The following is a description of a gene set: Neighborhood of AATF Human Gene Set: MORF_AATF species: Homo sapiens Neighborhood of AATF apoptosis antagonizing transcription factor in the MORF expression compendium, and this is the list of marker genes: XRCC5, ALG3, PIN1, DDX18, PPP2CA, ZBED1, CSK, CANX, PUM2, DNAJC11, SDHA, FIBP, PSMB7, POLR2I (RNA polymerase II subunit I), NUP188, SMNDC1 (NCBI Gene Id 10285), DYRK2, COPS5, CDK2, BUB3, TRAPPC3, IDH3A, TFAP4, SSBP1, DNAJC8, DAP3, POLR2A (RNA polymerase II subunit A), HUWE1, ACLY, SUMO2, ARFGAP2, PRKAG1, VDAC3, SART3, RPA2, LYPLA1, SNU13, POP5, SGTA, PSMD3, DEK, MDH1 (NCBI Gene Id 4190), SMARCC2, TUFM, PUF60, PRKCSH, GLUD1, CLNS1A, MCM2, HSPA8, ATXN10, EIF1AX, COQ9, TERF2IP, XPO7, PSMB3, PREP, EIF6, RPN1, SRRM1, SUMO4, CNPPD1, NAE1, AIMP2, CALM2, PSMD2, VARS1, SNRPA (small nuclear ribonucleoprotein polypeptide A), MTOR, PABPN1, POM121, SDR39U1, ADSL, ZZZ3, NUDT3, IARS1, STARD7, PRPF8, MRPL9, FUS, PRPF31, EIF4H, CAPZA1, CAD, HADH, HNRNPD, AGPAT1, EIF2B5 (NCBI Gene Id 8893), PHB1, ZPR1, SERBP1, PTDSS1, TIMM17A, KDM3B, NELFB, IK, PKMYT1, RUVBL1, AHSA1, NUP62, ESYT1, EIF3M, TXLNA, NAP1L4, SFSWAP, HNRNPAB, USP5, COPS6, HDAC2, CUL1, DHX38, PHB2, GPAA1, LRPPRC, NONO, ETF1, TCOF1, BAZ1B, UBE2I, SERP1, ILF2, CNP, METAP1, ANAPC5, TIAL1, OXA1L, IMMT, CLSTN1, LSM7, DDX39A, KXD1, ICE1, MLEC, RUVBL2, CNOT1, PRKDC, EIF3I, PABPC4, TP53BP1, ASH2L, RAD23A, WDR18, SSB, AFG3L2, LSM2, HADHB, GPN1, AATF, USP1, ZNHIT3, POLR2C, MTX1, CS (NCBI Gene Id 94822), MCM5, CAPRIN1, THOP1, EIF3K, DDB1, SEPTIN7, XPO6, TEX261, SAFB, IDH3B, HNRNPA2B1, SNRNP200, CASC3, BMS1, DDX49, YWHAQ, POLE3, RTCB, BRD8, CTDNEP1, GNL2, XPO1, PWP1, ARIH2 (NCBI Gene Id 10425), TRRAP, SCARB1, RNPS1, CYC1, CEBPZ, KHDRBS1, ZC3H15, EPRS1, CCT4, GTF2A2 (general transcription factor IIA subunit 2), MFN2, VDAC2, TCEA1, SSRP1, ACTL6A, DRG1, HNRNPU, PSMB6, KAT2A, ALDH4A1, DDX39B, SRRT, RALY, SET, NCL, CCT2, EBP, HNRNPC, UBE2L3, PDE6D, NUDC, MMS19